The following is a description of a gene set: Human Gene Set: GSE2405_0H_VS_9H_A_PHAGOCYTOPHILUM_STIM_NEUTROPHIL_UP Genes up-regulated in polymorphonuclear leukocytes (9h): control versus infection by A. phagocytophilum. studied in species Homo sapiens Polymorphonuclear leukocytes (PMNs) were obtained from healthy individuals in accordance with protocols approved by the Institutional Review Board for Human Subjects at the University of Minnesota and the National Institute of Allergy and Infectious Diseases. PMNs (107) were combined on ice with live S. aureus (108) or with live or heat-killed A. phagocytophilum (bacteria isolated from 5x106 infected HL60 cells for a ratio of 1 infected HL60 cell: 2 PMNs, ~ 5-20 A. phagocytophilum: PMN) in wells of a 12-well tissue culture plate (pre-coated with 20% autologous normal human serum). Unstimulated control assays received either buffer (for S. aureus comparisons) or clarified HL60 lysate (for A. phagocytophilum comparisons). Plates were centrifuged at 350 x g for 8 min at 4oC to synchronize phagocytosis and incubated at 37 deg. C in a CO2 incubator for the indicated times. At the indicated times, tissue culture medium was aspirated from the plate and PMNs were lysed directly with RLT buffer (Qiagen, Valencia, CA). Purification of PMN RNA and subsequent preparation of labeled cRNA target was performed as described in Methods. Labeling of samples, hybridization of cRNA with HU133A oligonucleotide arrays (Affymetrix, Santa Clara, CA), and scanning were performed according to standard Affymetrix protocols ( http://www.affymetrix.com/pdf/expression_manual.pdf ). Experiments were performed in triplicate, using PMNs from three healthy individuals for each treatment. from publication Borjesson DL, Kobayashi SD, Whitney AR, Voyich JM, Argue CM, Deleo FR (PMID 15879137), and this is the list of marker genes: SCUBE3, UBL3, RAP1GAP2, PRPF8, PSMA1, SPPL3, TRMT2A, TEX9, TMEM212, RTF1, U2AF1, PRKCD, RHBDF1, SLC25A45, SP3, ZBTB43, TAFAZZIN, SESN2, TDRD12, SPACA4, PRSS36 (NCBI Gene Id 146547), SLC9C2, POU2F2, PMAIP1, CPNE3, RSBN1, RAD54L2, RD3, TMEM14A, SLCO3A1, UBIAD1, SRSF11, SH3YL1, SH3GLB1, XRCC5, ZNF484, TBC1D4, SHCBP1L, APOD, SLC43A1, TKT, SIAH3, VIM, ZNF329, PKN1, SNORD6, TMEM176B, TOX2, SACS, TRAV8-3, SPOCD1, TAAR5, TAF12, POU4F1, VMAC, SERTAD3 (SERTA domain containing 3), SLC3A2, PIGF, PHTF1, SETD5, RNF145, TMEM81, SPRYD7, RALGDS, TMEM132E, RTTN, TPPP2, TBC1D24, SMC4, SNORD53, SNORA14B, RNF34, ZNF396, TM4SF20, PRSS30P, POP5, ZNF749, SLX4, RRP1B, TMPRSS3, TCIRG1, TYW1B, ZNF45, TPST2, SNORA51, PIP5K1B, RAPGEFL1, SRSF12, RAB3GAP1, STK17B, PDLIM3, SNAP91, PRKAG2, TRIM38, PRSS33, PNKP, RARRES1, SLC9A4, XDH, PPIF, THAP4, RAB39B, ZNF841, STAM2, TLX2, SCN7A, TUBB2A, KMT5A, PDHB, SMARCA1, ZNF621, PPIAP26, SMTNL2, SUV39H1, RECQL4, PPP3R2, SLC31A1, USP20, REC8, PHTF2, ODAD4, SHISA7, PPP1R15A, SLC37A3, TLR5, RSBN1L, POM121L12, ZNF106, TGFB3, PDX1, PEX19, RNASET2, SLC4A1AP, PDXK, ZRANB3, PLEKHM2, ZNF85, SNORD38A, SNX17, ZNF672, PSME4, SESTD1, SNORD63, TXN, MRM3, VCL, SPRR2E, REEP3, SH3BP5, SMARCA4, PRPS1, TBC1D20, UNC119B (unc-119 lipid binding chaperone B), SSH2, SLC4A5, ZNF781, PELI3, SP1, PTS, TRAF3, SLC10A6, ZNF648, TXNDC16, SUGT1, SMU1, RFX5, ZNF808, SLC6A20, ZNF620, RIMS3, RGS9BP, TM4SF5, SPATA20, SNX25, UAP1L1, YTHDC2, TRMT61A, PRDX3, ZBED5, RIF1, SNORA33, ZSCAN12, ZRANB1, TNFRSF13B, SCN1A (sodium voltage-gated channel alpha subunit 1), TRA2A, SGMS1, ZAR1L, USHBP1, TUBA1B, PHF19 (PHD finger protein 19), SLC29A2 (solute carrier family 29 member 2), PHF8 (NCBI Gene Id 57793), PRSS27 (serine protease 27), PHF21B, WNT5A, SLC35F2, SPATS1